The following is a description of a gene set: studied in species Mus musculus Genes positively differentially expressed in cell type: B cell upon treatment with cytokine: IFN-ε in mouse lymph nodes in vivo. from publication Cui A, Huang T, Li S, Ma A, Pérez JL, Sander C, Keskin DB, Wu CJ, Fraenkel E, Hacohen N (PMID 38057668) Mouse Gene Set: CUI_B_CELL_IFNE_RESPONSE_UP Cytokines mediate cell-cell communication in the immune system and represent important therapeutic targets. A myriad of studies have highlighted their central role in immune function, yet we lack a global view of the cellular responses of each immune cell type to each cytokine. To address this gap, the authors created the Immune Dictionary, a compendium of single-cell transcriptomic profiles of more than 17 immune cell types in response to each of 86 cytokines (>1,400 cytokine-cell type combinations) in mouse lymph nodes in vivo. A cytokine-centric view of the dictionary revealed that most cytokines induce highly cell-type-specific responses. For example, the inflammatory cytokine interleukin-1β induces distinct gene programmes in almost every cell type. A cell-type-centric view of the dictionary identified more than 66 cytokine-driven cellular polarization states across immune cell types, including previously uncharacterized states such as an interleukin-18-induced polyfunctional natural killer cell state., and this is the list of marker genes: Ifi35, Trim30a, Ifi209, Isg15, Slfn5, Ifi206, Xaf1, Cd8b1, Oasl2, Rnf213, Tor3a, Eif2ak2, Stat1, Pml, Zbp1, Ifi27l2a, Ifitm3, Sp100, Rigi, Parp14, Ly6a, Slfn2, Tlr7, Oasl1, Ms4a4c, Ifi213, Ifit3, Cd47, Shisa5, Isg20, Phf11b, Rtp4, Tspo, Ifi208, Irgm1, Mndal, Ifi47, Ifi203, Plac8, Psme1, Bst2, Irf7